The following is a description of a gene set: Genes positively differentially expressed in cell type: pDC (plasmacytoid dendritic cell) upon treatment with cytokine: IFN-γ in mouse lymph nodes in vivo. from publication Cui A, Huang T, Li S, Ma A, Pérez JL, Sander C, Keskin DB, Wu CJ, Fraenkel E, Hacohen N (PMID 38057668) Cytokines mediate cell-cell communication in the immune system and represent important therapeutic targets. A myriad of studies have highlighted their central role in immune function, yet we lack a global view of the cellular responses of each immune cell type to each cytokine. To address this gap, the authors created the Immune Dictionary, a compendium of single-cell transcriptomic profiles of more than 17 immune cell types in response to each of 86 cytokines (>1,400 cytokine-cell type combinations) in mouse lymph nodes in vivo. A cytokine-centric view of the dictionary revealed that most cytokines induce highly cell-type-specific responses. For example, the inflammatory cytokine interleukin-1β induces distinct gene programmes in almost every cell type. A cell-type-centric view of the dictionary identified more than 66 cytokine-driven cellular polarization states across immune cell types, including previously uncharacterized states such as an interleukin-18-induced polyfunctional natural killer cell state. species: Mus musculus Mouse Gene Set: CUI_PDC_IFNG_RESPONSE_UP, and this is the list of marker genes: Tspo, Nudt19, H2-D1, Mrpl55, Mcee, Wars1, Ube2l6, Ifi204, Sharpin, Dtx3l, Irf8, Pkib, Parp14, Ppa1, Eif2ak2, Ptprc, Acadl, Stat2, B2m, Psma7, Psmb8, Samhd1, Calhm6 (calcium homeostasis modulator family member 6), Ifi203, Rap1a, Gbp8 (guanylate-binding protein 8), Tmsb10, Tapbpl, Mpeg1, Kdr, H2-T23, Socs1, Irgm1, Gbp3, Nmi, Ly6a, Psme2, Ifi27l2a, Glrx (NCBI Gene Id 97899), Irf1, Ifi47, Psmb9, Psmb2, Plac8, Dbnl, M6pr (mannose-6-phosphate receptor, cation dependent), Tmco6, Ly6c2, Iigp1, Atp6ap1, Plaat3, Serpina3f, Rsbn1l, Pfn1, Pmepa1, Psma4, Atp6v1d, Nlrc5, Slc4a8, Abhd17b (abhydrolase domain containing 17B), Ly86, Tmbim6, Creb3, Irgm2, Ifitm3, Serpina3g, Ctsc, Shisa5, Igtp, Fnbp4, Prodh, Mndal, Pdp2, Csf2rb, Tap2, H2-K1, Hck, Stat1, Sp110 (Sp110 nuclear body protein), Ifi207, Usp18, Sdc3, Parp9, Lgals3bp, Gbp6, Atm, Gbp4, Zbp1, Nsmce1, Ifi213, Csf2rb2, Rnf213, Irf7, Pdzd11, Gbp7, Gsap, Slfn5, Nampt, Tap1, Sct, Isg15, Sgcb, H2-Q4, Gbp5, Arf4, Cd47